Given this list of marker genes FLCN, NF1, CASR, IDH2, IFNG, CDKN1B, RET, ZFX, MEN1, PRDM10, IDH1, CDKN2C, SLC12A3, TSC2, CLCNKB, CDKN1A, GCM2, TSC1, CDC73, CDKN2B, here is a description of the gene set: Neoplasm of the parathyroid gland Human Gene Set: HP_NEOPLASM_OF_THE_PARATHYROID_GLAND studied in species Homo sapiens A tumor (abnormal growth of tissue) of the parathyroid gland.